The following is a description of a gene set: Sick sinus syndrome An abnormality involving the generation of the action potential by the sinus node and is characterized by an atrial rate inappropriate for physiological requirements. Manifestations include severe sinus bradycardia, sinus pauses or arrest, sinus node exit block, chronic atrial tachyarrhythmias, alternating periods of atrial bradyarrhythmias and tachyarrhythmias, and inappropriate responses of heart rate during exercise or stress. Human Gene Set: HP_SICK_SINUS_SYNDROME species: Homo sapiens, and this is the list of marker genes: AKAP9, KCNJ8, SGO1, SCN5A, KCNE5, RANGRF, SCN2B, RYR2, CACNA1C, SCNN1A, SCN10A, SCN1B, CACNB2, HCN4, CACNA2D1, TRDN, TRPM4, ABCC9, GNB5, NPPA, KCND3 (potassium voltage-gated channel subfamily D member 3), MYH6, KCNE3, GPD1L, SCN3B, PKP2, SEMA3A, SLMAP, CASQ2